The following is a description of a gene set: Human Gene Set: HP_ACIDEMIA Acidemia species: Homo sapiens An abnormally low blood pH (usually defined as less than 7.35)., and this is the list of marker genes: ETFB, MTRR, PAH, SUGCT (NCBI Gene Id 79783), HCFC1, SUCLA2, MMUT, IDH2, PAX4, ACSF3, SUCLG1, ALDH6A1, MMAB, DNAJC19 (DnaJ heat shock protein family (Hsp40) member C19), L2HGDH, ETFA, GCDH (glutaryl-CoA dehydrogenase), CD320, MMADHC, PRDX1, ABCD4, MMAA, MMACHC, LMBRD1, ETFDH